Given this list of marker genes KIF9, KDELR1, KIF3A, KIF18B, RAB1A, ARF3, KLC1, KIF5A (NCBI Gene Id 84710), KIF4A, KIF21A, SURF4, KIF3B, KIF25, TUBB8B, ARF1, KIF2B, ARFGAP1, TUBB6, KIF15, KIFC1, KIF1B, TMED10, NSF, ARFGAP3, KIF23, KIF1A, ARF4, RAB1B, TUBAL3, TUBB4B, RACGAP1, KIF12, BNIP1, TUBA4A, NAPA, KIF5B, KLC2, COPB2 (COPI coat complex subunit beta 2), GBF1, TUBA1B, KIFC2, KIF11, STX18, KIF16B, TUBA3D, KIF27, KIF26B, TUBA3E, COPG1, CENPE, KIF19, ARF5, RINT1, TUBB1, COPZ2, TUBA8 (tubulin alpha 8), KDELR3, ARFGAP2, KIF22, TUBA4B (tubulin alpha 4b), USE1, KIF1C, TUBA1C, ZW10, KIF20A, COPB1, KIF6, KIF18A, NAPG, ARCN1, KIFAP3, KIF26A, NAPB, TMED7, KIF2C, TMED3, KIF3C, TMED9, KLC3, KIF2A, TMED2, KIF20B, SEC22B, TUBB2A, TUBB2B, KIF21B, COPE, COPG2, KIF4B, KLC4, KDELR2, KIF13B, TUBB4A, TUBA3C, NBAS, TUBB8, TUBB3, COPZ1, COPA, TUBA1A, here is a description of the gene set: species: Homo sapiens COPI-dependent Golgi-to-ER retrograde traffic Human Gene Set: REACTOME_COPI_DEPENDENT_GOLGI_TO_ER_RETROGRADE_TRAFFIC